The following is a description of a gene set: electronically inferred by orthology from the curated human pathway part of: Signaling by FGFR4 This event has been computationally inferred from an event that has been demonstrated in another species.<p>The inference is based on the homology mapping from PANTHER. Briefly, reactions for which all involved PhysicalEntities (in input, output and catalyst) have a mapped orthologue/paralogue (for complexes at least 75% of components must have a mapping) are inferred to the other species. Reactome Pathway: Downstream signaling of activated FGFR4 species: Mus musculus, and this is the list of marker genes: Fgf20, Fgf4, Fgf17, Grb2, Frs2, Fgf8, Fgf1, Fgf2, Gab1, Fgf15, Klb, Fgf16, Hras, Shc1, Fgf6, Fgf23